The following is a description of a gene set: studied in species Homo sapiens Neighborhood of LCAT lecithin-cholesterol acyltransferase in the GNF2 expression compendium Human Gene Set: GNF2_LCAT Neighborhood of LCAT, and this is the list of marker genes: CEBPA, ZG16, ADH6, AGXT, IGFALS, CYP4F2, APCS, C4BPB, SERPINA4, SERPING1 (NCBI Gene Id 710), F12, ORM1, PXMP2, AMBP, SAA4, FAH, HPN, APOC2, SERPINC1, APOF, C8G, PEMT, TAT, GSTM1, VTN, SLC27A5, ANGPTL8, CYP2B6, UPB1, MAT1A, TST, APOC3, HAMP, SLC22A7, F10, ALDH1L1 (aldehyde dehydrogenase 1 family member L1), PROC (protein C, inactivator of coagulation factors Va and VIIIa), TMEM176A, ANG (angiogenin), ITIH1, FTCD, HMGCS2, CDHR5, GSTM2, RBP4, FETUB, C8A, CYP2E1, C3, APOA1, PIPOX, TM4SF5, PON1, CYP2C8, HGFAC, NNMT, CYP4F11, HABP2, CES2, SLC10A1 (NCBI Gene Id 6554), ECHS1 (enoyl-CoA hydratase, short chain 1), F2, C6, SARDH, CYP4A11, KHK, ITIH3, GNMT, CYP27A1, TMPRSS6, PCK1, HRG, HAAO, GSTZ1, TFR2, SLC38A3, CFB, CYP2D6, ACOX2, ALDH4A1, SERPINF2, HP, AKR7A3, ORM2, CYP2A6, APOA2, CYP1A2, SPP2, APOC1, ZGPAT, GAMT, ASL, TMEM176B, APOC4, LCAT, AHSG, SDS, C4BPA, GJB1, ABCC6, TKFC, CYP2C9, HPD, CYP4F12, SLC22A1, MASP2, HMGCL (NCBI Gene Id 3155), ITIH4, CES1, ASGR2 (NCBI Gene Id 433), CIDEB, HPR, HPX, ATF5, SLC25A10 (NCBI Gene Id 1468), PON3, RARRES2, DCXR, RDH16, CPN2, HSD17B6, ADH1C, PKLR, SERPIND1